The following is a description of a gene set: species: Homo sapiens Human Gene Set: GOBP_INTRINSIC_APOPTOTIC_SIGNALING_PATHWAY_IN_RESPONSE_TO_DNA_DAMAGE The series of molecular signals in which an intracellular signal is conveyed to trigger the apoptotic death of a cell. The pathway is induced by the detection of DNA damage, and ends when the execution phase of apoptosis is triggered., and this is the list of marker genes: MIF, CD44, SNW1, EP300 (NCBI Gene Id 2033), SOD2, NACC2, SHISA5, MUC1, UACA, KDM1A, TNFRSF1A, BCL2L12, BCL3, CDKN1A, EI24, XPA, CHEK2, PRKDC, CIDEB, RAD9A, CRIP1, NFATC4, RPS27L, MSH6, TAF9, E2F1, IFI16 (NCBI Gene Id 3428), USP47, CASP9, TP63, RPS3, SFN, PIK3R1, TRIAP1, ZNF385A, MCL1, ELL3, PHLDA3, HIC1, ING2, DDIAS, MOAP1, BCL2, URI1, MLH1, HIPK2, MARCHF7, MAEL, DDIT4, TRIM32, IER3, BAX, CLU, TAF9B, BCL2L10, PIAS4, FBH1, CD74, HTRA2, AEN, BRCA1, TMEM161A, SFRP2, BCL2L11 (NCBI Gene Id 150819), SIRT1, CASP2, RPL26, PML, TP53, BAG6, TMEM109, TPT1, EPHA2, BAD, CDKN2D, HIPK1, TP73, TNF, SKIL, BAK1, BCL2L2, BCL2L1, NUPR1, PPP2R5C, FNIP2, TOPORS, CCAR2, CDIP1, HNRNPK, SNAI2, ATAD5, PYCARD, BCL2A1, TNFRSF1B, POLB, ABL1, DYRK2, ERCC6, BBC3, MYC, USP28, ATM, BID, IKBKE, MTCH2, BOK, ACKR3, BRCA2, CXCL12, MSH2 (NCBI Gene Id 8169), SNAI1